Given this list of marker genes Msi2, Nipbl, Tfcp2l1, Smarcd1 (SWI/SNF related, matrix associated, actin dependent regulator of chromatin, subfamily d, member 1), Nmral1, Frmd7, Tlx1 (T cell leukemia, homeobox 1), Uqcc1, Hnrnpu, Cdc40, Gtpbp1, Sptb, Eef1ece2, Nlrp1a, Dcun1d4, Iqsec2, Kbtbd11, Mideas, Ulk2, Cers2, Trmt2a, Iqsec1, Ubr3, Car13, Naa10, Isoc2b, Mybpc1, Tsc22d1, Zfr2, Nat8f2, Plekhm1, Nudt3, Nudt18, Asph, Atp11a, Srxn1, Os9, Pyroxd1, Rit2, Txlna, Nell2, Bop1, Rpp40, Acot11, Rdx, Slc1a2, Il13ra1, Ece2, Mtmr2, Fut4, Ido2, Serping1, Pax1, Dhcr24, Dcaf17, Zdhhc9, Thada, Lrsam1, Nr4a1, Zfp781b, Ifit1bl2, Iqsec3, Grm7, here is a description of the gene set: species: Mus musculus Mouse Gene Set: MIR_12193_5P Genes predicted to be targets of miRBase v22 microRNA mmu_miR_12193_5p in miRDB v6.0 with MirTarget v4 prediction scores > 80 (high confidence targets). from publication Chen Y, Wang X (PMID 31504780)